Given this list of marker genes HDC, ELL2, GNA13, GAB1, DSP (desmoplakin), ITGA2, CARHSP1 (calcium regulated heat stable protein 1), FCRLB, LCN2, CD14, ARID5A, WDFY1, BASP1, CD69, CCRL2, MCOLN2, RIPK2, ANXA8, SBNO2, VCAM1, MMP13, CLEC4E, DMKN, TNIP1, RASAL2, RAP1B, CASP4, MALT1, KRT1, PERP, NDRG1, RAPGEF2, SLC25A37, GFOD1 (NCBI Gene Id 96191), ALAS1, TNFRSF1B, MX1, KRT10, GADD45B, SMOX, TARM1, ADORA3, RSAD2, SOCS3, CXCL3, NFKB1, CHD7, TNFAIP2, SIPA1L1, INPP5B, SLCO3A1, STX6, ASCC3 (activating signal cointegrator 1 complex subunit 3), MT1A, GLIPR2, RIN2, MXD1, RIOK3 (RIO kinase 3), IL1RN, EML2, CXCL2, PTGS2, FTH1, IL10, RND1, DSC3, HK2, CLEC4D (C-type lectin domain family 4 member D), SAA3P, KRT14, IKBKE, NFKB2, CYTH3, PTP4A1, DSG3, IRAK3, IL7R, AMPD3, GPR35, TNIP3, DUSP1, HCAR2, EDN1, EBI3, TNF (tumor necrosis factor), IL12B, STK40, ASPRV1, GREM1 (gremlin 1, DAN family BMP antagonist), DTX2, GYS1, TNFRSF9, SMPDL3B, CCL7, NUPR1, NFKBIA, ADORA2B, CPEB2, HTRA4, SERPINB5, IL15RA, FPR1, CD40, KRT5, SLC7A11, NFKBIB, CLIC4, DUSP2, NFKBIZ, TTC39C, MT2A, SAMSN1, CCL5, OPTN, PIM1, ANK3 (ankyrin 3), MX2, MSRB1, ACOD1, BLTP3B, ADAM8, TREM1, TARS1, HIF1A, PIK3R5, MFHAS1, DMXL2, IL1A, KRTDAP (keratinocyte differentiation associated protein), CFLAR, TET2, PICALM, OXSR1, TCIRG1, MAP3K8, NOS2, IL36G, NRG1, RNF149, FNDC3A, SLAMF7, PDE4B, SLC2A1, CCL3, PDPN, IL1RL1, KTN1, PLEK, RBPMS, OASL, FOXP1, STX11, CSF3R, FAS, ELOVL7, IER5, CD274, ZFP36, TNFSF9, CXCR2, CCL4, SOD2, IL1B, SLC15A3, PFKFB3, S100A9, PPME1, IL6, DUSP16, CCL2, FURIN, SLC39A14, BCL3, FMNL2, HIVEP2 (NCBI Gene Id 3097), PROCR, PTGES, SLC13A3, PVR, GCNT2, CD200, TNFAIP3, here is a description of the gene set: Genes up-regulated in memory CD8 T cells: 2' versus 4'. from publication Wirth TC, Xue HH, Rai D, Sabel JT, Bair T, Harty JT, Badovinac VP (PMID 20619696) Human Gene Set: GSE21360_SECONDARY_VS_QUATERNARY_MEMORY_CD8_TCELL_UP The transcriptome of naive OT-I T cells was compared to memory CD8 T cells after 1, 2, 3, or 4 infection with ovalbumin expressing Listeria monocytogenes (LM-OVA). species: Homo sapiens